The following is a description of a gene set: The process whose specific outcome is the progression of cardiac muscle over time, from its formation to the mature structure. Human Gene Set: GOBP_CARDIAC_MUSCLE_TISSUE_DEVELOPMENT studied in species Homo sapiens, and this is the list of marker genes: NOX4, FHOD3, PROX1, NRG1, NEB, MEF2A, BMPR1A, PKP2, SMAD5, NDUFV2, EFNB2, ERBB3, SGCD, HOPX, CAV3, ZFPM1, MIR200B, MSX2, SGCB, NOTCH1, ADRA1A (adrenoceptor alpha 1A, NCBI Gene Id 148), NPRL3, TNNI3, WT1, MIR19A, DKK1, FZD7, MYL3, MIR195, SIK1, HNRNPU, ALPK3, ERBB4, CALR, PRMT1, TENM4, PTCD2, ZMPSTE24, MYOCD, MIR1-1, RARA, FGFR1, SCN5A, PRKG1, SAV1, CTDP1, GJA5, FOXC1, BMP4, ATG5, IFT20, GLI1, KCNK2, BVES, PPP1R13L, MAPK14, WNT3A, GJA1, MYLK2, SGCZ, PLEC, TGFB2, DIPK2A, GREM1, NEBL, ABL1, MIR548C, RGS2, DLL4, CTCF, BMP2, TREX1, MIR19B1, MIR24-1, KDM6B, MYH7 (NCBI Gene Id 8090), FOXP1, NOG, MAPK11, BMP7, MEIS1, JPH2, MIR590, MIR509-1, ACVR1, MIR208A, MYLK3, NKX2-5, MED1, MBD3, ALDH1A2, MSC, CREB1, ZFPM2, KRAS, RARB, SGCG, ADAMTS9, COL11A1, YY1, ARRB2, MTOR, HAND1, ACTC1, TOMM70, ACTN2, PPARA, MAML1, SRF, XIRP2, ARID2, SHOX2, ALPK2, TBX2, KCNJ11, NPPB, FOXH1, VGLL4, FES, VEGFA, OBSL1, ACADM, TNNT2, MIR199B, LMNA, TSC1, RGS4, HDAC3, FOXC2, MYH6, PAK1, SMAD4, NPPA, MIR23A, PDGFRB, RBPJ, S1PR1, MESP1, DSP, JARID2, GJB6, NOTCH2, TCAP, LRRC10, CCNB1, NRAP, FGF9, IRX3, TGFBR1, LARGE1, MEF2C, PITX2, GATA5, HEY1, FGF2, EGLN1, LRP2, NKX2-6, PLN, BMP10, IGF1, RXRB, CACYBP, TNNC1, COL14A1, ZIC3, PI16, HEY2, MYH10, AKAP13, SOX6 (NCBI Gene Id 84363), TTN, MIR199A1, NAGLU, KCNJ8, PDLIM5, CBY1, YAP1, WNT2, SKI, POU4F1, TBX3, MYL7, MIR17HG, MIR25, NDRG4, RUNX1, PRICKLE1, CDK1, TP73, SMAD1, EDN1, C10orf71, FGF3, GATA6 (GATA binding protein 6), G6PD, MBD2, FGF20, BMPR2, ITGB1, MIR499A, GSK3A, TGFB1, KAT2A, EDNRA, MYH11, RBP4, CHD7, CACNA1G, TBX18, SIRT6, GJC1, PRKAR1A, ISL1, PDGFRA, FKBP1A, MYL2, ASB2, DSG2, FRS2, MIR222, MYBPC3, SLC9A1, FHL2, MSX1, PIM1, ANKRD1, TGFBR3, TBX20, BMP5 (NCBI Gene Id 653), UBE4B, ADPRHL1, TPM1, SORBS2, RYR2, TBX5, MYO18B, GREB1L, FGF8, MIR873, ENG, FGFR2, SLC8A1, TNNI1, CDC42, PARP2, HCN4, CSRP3, DLL1, ID2 (inhibitor of DNA binding 2), AKAP6, HEG1, SMAD7, GATA4, CXADR, MIR204